The following is a description of a gene set: Up-regulated target genes shared by acute myeloid leukemia (AML) translocation products PML RARA, AML1 ETO, and PLZF RARA. Human Gene Set: MUELLER_COMMON_TARGETS_OF_AML_FUSIONS_UP studied in species Homo sapiens from publication Müller-Tidow C, Steffen B, Cauvet T, Tickenbrock L, Ji P, Diederichs S, Sargin B, Köhler G, Stelljes M, Puccetti E, Ruthardt M, deVos S, Hiebert SW, Koeffler HP, Berdel WE, Serve H (PMID 15024077) The acute myeloid leukemia (AML)-associated translocation products AML1-ETO, PML-retinoic acid receptor alpha (RARalpha), and PLZF-RARalpha encode aberrant transcription factors. Several lines of evidence suggest similar pathogenetic mechanisms for these fusion proteins. We used high-density oligonucleotide arrays to identify shared target genes in inducibly transfected U937 cells expressing AML1-ETO, PML-RARalpha, or PLZF-RARalpha. All three fusion proteins significantly repressed the expression of genes and induced the expression of genes. Several of the regulated genes were associated with Wnt signaling. One of these, plakoglobin (gamma-catenin), was induced on the mRNA and protein level by all three fusion proteins. In addition, primary AML blasts carrying one of the fusion proteins significantly overexpressed plakoglobin. The plakoglobin promoter was cloned and shown to be induced by AML1-ETO, with promoter activation depending on the corepressor and histone deacetylase binding domains. The induction of plakoglobin by AML fusion proteins led to downstream signaling and transactivation of TCF- and LEF-dependent promoters, including the c-myc promoter, which was found to be bound by plakoglobin in vivo after AML1-ETO expression. beta-Catenin protein levels and TCF and LEF target genes such as c-myc and cyclin D1 were found to be induced by the fusion proteins. On the functional level, a dominant negative TCF inhibited colony growth of AML1-ETO-positive Kasumi cells, whereas plakoglobin transfection into myeloid 32D cells enhanced proliferation and clonal growth. Injection of plakoglobin-expressing 32D cells into syngeneic mice accelerated the development of leukemia. Transduction of plakoglobin into primitive murine hematopoietic progenitor cells preserved the immature phenotype during colony growth, suggesting enhanced self-renewal. These data provide evidence that activation of Wnt signaling is a common feature of several balanced translocations in AML., and this is the list of marker genes: TLE5, CCNF, CITED2, JUP, PPP2R5D, SCAP, TCF3, HADHA, PAFAH1B3, SNX17, DNM2 (dynamin 2), SOX4, ARF5, CD99